The following is a description of a gene set: Binding to an interleukin-1 receptor. Mouse Gene Set: GOMF_INTERLEUKIN_1_RECEPTOR_BINDING studied in species Mus musculus, and this is the list of marker genes: Trip6, Il36rn, Myd88, Il1rn, Ticam2, Il1a, Tollip, Tlr5, Tlr9, Irak4, Il1rap, Irak1, Il1f10, Il1b, Il36a, Grin2b